Given this list of marker genes CASP4, CASP12, CASP5, NLRP1, PYCARD, CASP1, here is a description of the gene set: Human Gene Set: GOCC_NLRP1_INFLAMMASOME_COMPLEX An inflammasome complex that consists of two components, NLRP1 (NALP1) and caspase-1 or caspase-5. The exact mechanisms of NLRP1 activation remain obscure, but potassium ion efflux appears to be essential. species: Homo sapiens